The following is a description of a gene set: Mouse Gene Set: GOMF_C_X3_C_CHEMOKINE_BINDING species: Mus musculus Binding to a C-X3-C chemokine; C-X3-C chemokines have three amino acids between the first two cysteines of the characteristic four-cysteine motif., and this is the list of marker genes: Itgb1, Itgav, Itgb3, Itga4, Cx3cr1